Given this list of marker genes KAT7, PAX2, OTX2, CDC45, CRYAB, FLOT1 (flotillin 1), SEC23B, AKAP12, DHRS9, MRPL49, CPEB4, PREPL, PHF8, RPS6KA3, OSBPL11, ITGA5, ZNF174, ACTN1, PLOD1, MORN4, TIAM1, AP1G2, LHX6, SNX5, CORO6, HSPG2, HIF1A, PRKACA (protein kinase cAMP-activated catalytic subunit alpha), PSMB5, MLLT6, POGLUT1, NOB1, PRRG1, ITCH, MGME1, ZMYND8, ATP5MC2, NCDN, BAD, IGF1, HOXB5, DHX40, KPNA6, ECH1, STX10, GMPR, FEZF2, PDGFRA, CAMKMT, TIA1, LMO2, CHD6, FOXO4, HEMGN, IER3, ADCY2 (NCBI Gene Id 254679), IRF9, RALY, INHBA (NCBI Gene Id 3624), NR2F6, C9orf72, HSPB2, TBC1D14, CSNK2A1, MITF, NLK, ITGB1BP2, CNOT4, B3GALT6, PRKD2, NKIRAS2, TSPAN33, BRD3, IGF2R, TJAP1 (tight junction associated protein 1), TMUB2 (NCBI Gene Id 79089), IGF2BP1, ZNF524, USF1, TRIM54, PAGR1, FIZ1, SNAP25, GIT2, EDA, TAOK2, LINC01465, PPP2R3C, DEPTOR, DNAJC7, CNOT1, PTCHD4, IER2, ATOH1, RILPL2, SZRD1, CNR1, ZSCAN32, THAP1, SEPTIN7, IRX6, UFD1, CACNA1G, PTBP1, here is a description of the gene set: Human Gene Set: CCCNNNNNNAAGWT_UNKNOWN Comprehensive identification of all functional elements encoded in the human genome is a fundamental need in biomedical research. Here, we present a comparative analysis of the human, mouse, rat and dog genomes to create a systematic catalogue of common regulatory motifs in promoters and 3' untranslated regions (3' UTRs). The promoter analysis yields 174 candidate motifs, including most previously known transcription-factor binding sites and 105 new motifs. The 3'-UTR analysis yields 106 motifs likely to be involved in post-transcriptional regulation. Nearly one-half are associated with microRNAs (miRNAs), leading to the discovery of many new miRNA genes and their likely target genes. Our results suggest that previous estimates of the number of human miRNA genes were low, and that miRNAs regulate at least 20% of human genes. The overall results provide a systematic view of gene regulation in the human, which will be refined as additional mammalian genomes become available. species: Homo sapiens from publication Xie X, Lu J, Kulbokas EJ, Golub TR, Mootha V, Lindblad-Toh K, Lander ES, Kellis M (PMID 15735639) Genes having at least one occurrence of the highly conserved motif M158 CCCNNNNNNAAGWT in the regions spanning 4 kb centered on their transcription starting sites. The motif does not match any known transcription factor binding site.